Given this list of marker genes LSM2, SUGP1, HNRNPH2, U2AF1L4, POLR2G, GPKOW, SRRM1, PTBP1, GPATCH1 (G-patch domain containing 1), LENG1, YBX1, SF3B6, DHX15, RNU12, HSPA8, CRNKL1, DHX38, SRSF12, GCFC2, SLU7, PRPF31, PRKRIP1, FUS, DHX16, PCBP2, LUC7L3, NKAP (NCBI Gene Id 79576), HNRNPK, CWC15, CDC5L, MAGOHB, HNRNPA1, RBM22 (RNA binding motif protein 22), DDX23, RBM5, GTF2F1, NCBP1, SNRPA, SNU13, POLR2C, SNRPF, U2AF1, U2SURP, EFTUD2, PNN, HNRNPC, SART1, CHERP, ZMAT2 (NCBI Gene Id 153527, zinc finger matrin-type 2), TRA2B, HNRNPL, RBM42, CWC27, IK, CTNNBL1, POLR2B, SNRNP27, SDE2, RBM10, ACIN1, RBMX, SNRNP25, SRSF5, SRSF9, GTF2F2, POLR2K, HNRNPA2B1, PPIE, CDC40, SMNDC1, DNAJC8 (DnaJ heat shock protein family (Hsp40) member C8), EIF4A3, SNRNP40, U2AF2, SNRPC, SNIP1, WBP11, SNRPD1, BUD31, TFIP11, HNRNPA3, RNF113A, PHF5A, CWC22, SNRNP35, HNRNPD, NCBP2, MTREX (Mtr4 exosome RNA helicase), SF3A1, SF3B3, RBM17, CACTIN, SF3B4, CASC3, LSM6, PPP1R8, SNRPB, HNRNPU, PQBP1, UPF3B, SF3B5, PRCC, PRPF19, SRSF6 (NCBI Gene Id 6431), CWC25, POLR2L (RNA polymerase II, I and III subunit L), SMU1, WBP4, ALYREF, SRSF10, LSM5, SNRPB2, SNW1, PPIL1, LSM4, SRSF11, YJU2, LSM7, MAGOH, POLR2I, POLR2D, FAM50A, ZCRB1, WDR70, PCBP1, DDX5, SYF2, POLR2F, SF3B2, RBM7, SRSF8, PPIL2, HTATSF1, LSM3, HNRNPH1, PPIH, SNRNP48, RNU4ATAC, AQR, PRPF18, ZMAT5, RNPC3, POLR2A, DDX41, SAP18, PDCD7, PUF60, PPWD1, DHX8, CCAR1, PRPF4, PPIL4, C9orf78, ZNF830, SRSF1, SRSF4 (serine and arginine rich splicing factor 4), SNRPG, RBM25, POLR2J, SNRPE, SRRM2, HNRNPR, USP39 (NCBI Gene Id 10713), PLRG1, DHX9, HNRNPM, SNRPN, DDX46, SRSF3, RNPS1, MFAP1, SNRNP200, PRPF38A, SF3B1, RBMX2, HNRNPF, LSM8, POLR2E, DHX35, CWF19L2, TCERG1, ISY1, SNRPD3, SNRPD2, PRPF3, FAM32A, RBM8A, SRSF2, RNU11, SF3A2, UBL5, PPIL3, SRSF7, ZRSR2, PPIG, SNRPA1, STEEP1, PRPF8, XAB2, BUD13, PRPF40A, DDX39B, SNRNP70, POLR2H, NSRP1, SF1, BCAS2, CCDC12, SRRT, DDX42, PRP4K, SF3A3, RBM39, PRPF6, TXNL4A, here is a description of the gene set: The process in which excision of introns from the primary transcript of messenger RNA (mRNA) is followed by ligation of the two exon termini exposed by removal of each intron, is called mRNA splicing. Most of the mRNA is spliced by the major pathway, involving the U1, U2, U4, U5 and U6 snRNPs. A minor fraction, about 1 %, of the mRNAs are spliced via the U12 dependent pathway. Reactome Pathway: mRNA Splicing part of: Processing of Capped Intron-Containing Pre-mRNA species: Homo sapiens